The following is a description of a gene set: Human Gene Set: GOBP_POSITIVE_REGULATION_OF_VASCULAR_ASSOCIATED_SMOOTH_MUSCLE_CELL_APOPTOTIC_PROCESS studied in species Homo sapiens Any process that activates or increases the frequency, rate or extent of vascular associated smooth muscle cell apoptotic process., and this is the list of marker genes: PDCD4, MIR24-1, MIR1-1, MIR140, RBM10, ATF4, ADCY10, SOD2, E2F3, MFN2, PPARG